The following is a description of a gene set: studied in species Homo sapiens Human Gene Set: GOBP_REGULATION_OF_COLLAGEN_METABOLIC_PROCESS Any process that modulates the frequency, rate or extent of the chemical reactions and pathways resulting in the metabolism of collagen, any of a group of fibrous proteins of very high tensile strength that form the main component of connective tissue in animals., and this is the list of marker genes: CREB3L1 (cAMP responsive element binding protein 3 like 1), NPPC, SUCO, INHBA, MIR29B1, IL6, ITGB1, MYB, MIR29A, SERPINF2, SERPINB7, MIR149, VSIR, RAP1A, F2R, CST3, UCN, CIITA, PRDX5, CBX8, MIR92A1, GOT1, LARP6, NOTCH1, CYGB, F2, BMP4, SCX, EMILIN1, IHH (NCBI Gene Id 50819), AMELX, MIR145, IL6R, MIR218-1, PPARD, CYP7A1, VIM, MFAP4, RUNX1, RGCC, FAP, DDR2, TGFB3, ERRFI1, WNT4, ITGA2, TGFB1